Given this list of marker genes Ly6c1, Igfbp4, Ly6e, Ccnd3, Ly6a, here is a description of the gene set: Mouse Gene Set: CUI_T_CELL_CD4_LIF_RESPONSE_UP Cytokines mediate cell-cell communication in the immune system and represent important therapeutic targets. A myriad of studies have highlighted their central role in immune function, yet we lack a global view of the cellular responses of each immune cell type to each cytokine. To address this gap, the authors created the Immune Dictionary, a compendium of single-cell transcriptomic profiles of more than 17 immune cell types in response to each of 86 cytokines (>1,400 cytokine-cell type combinations) in mouse lymph nodes in vivo. A cytokine-centric view of the dictionary revealed that most cytokines induce highly cell-type-specific responses. For example, the inflammatory cytokine interleukin-1β induces distinct gene programmes in almost every cell type. A cell-type-centric view of the dictionary identified more than 66 cytokine-driven cellular polarization states across immune cell types, including previously uncharacterized states such as an interleukin-18-induced polyfunctional natural killer cell state. Genes positively differentially expressed in cell type: CD4+ T cell upon treatment with cytokine: LIF in mouse lymph nodes in vivo. from publication Cui A, Huang T, Li S, Ma A, Pérez JL, Sander C, Keskin DB, Wu CJ, Fraenkel E, Hacohen N (PMID 38057668) species: Mus musculus